Given this list of marker genes Lhx1, Mir216a, Pax2, Bmp4 (NCBI Gene Id 12159), Epha4, Pkd1, Wnt9b, Efnb2, Gata3, Mir217, Wnt11, Pkd2, Epha7, Greb1l, Gpc3, Osr1, Hnf1b, Mir216b, here is a description of the gene set: Mouse Gene Set: GOBP_NEPHRIC_DUCT_DEVELOPMENT species: Mus musculus The process whose specific outcome is the progression of a nephric duct over time, from its initial formation to a mature structure. A nephric duct is a tube that drains a primitive kidney.